Given this list of marker genes PGM3 (NCBI Gene Id 5238), GNPNAT1, GNPDA2, NANS, GNE, NAGK, GNPDA1, UAP1L1, UAP1, GFPT1, GFPT2, AMDHD2, NANP, here is a description of the gene set: species: Homo sapiens Human Gene Set: GOBP_AMINO_SUGAR_BIOSYNTHETIC_PROCESS The chemical reactions and pathways resulting in the formation of any amino sugar, sugars containing an amino group in place of a hydroxyl group.